Given this list of marker genes CHD6, FGFR1, GNRH1, COL17A1, KRT74, LAMC2, ITGB4, CDH3, AHSG, SNRPE, TAC3, HS6ST1, LAMA3, HRURF, FGF17, NSMF, NHLH2, JUP, FMR1, KISS1, RPL21, KISS1R, DUSP6, KRT85, KANK2, PROK2, CLDN1 (claudin 1), LAMB3, ST14, KLHL24, WDR11, EDA2R, ZBTB20, FGF8, DSC3, KRT71, LSS, CTSC, KRT25, ITGB6, EDA, DSG4, CST6, TP63, AXIN2, EDAR, WNT10A, LMNA, SPRY4, SOX18, TACR3, APCDD1, GNRHR, TRAF6, CYB5A, LIPH, PROKR2, EDARADD, CYP17A1, KDF1, LPAR6, CHD7, here is a description of the gene set: studied in species Homo sapiens Sparse body hair Sparseness of the body hair. Human Gene Set: HP_SPARSE_BODY_HAIR